The following is a description of a gene set: species: Homo sapiens Thickened toenails. Onychogryphosis of toenails Human Gene Set: HP_ONYCHOGRYPHOSIS_OF_TOENAILS, and this is the list of marker genes: COL7A1, KLHL24, KRT6B, PLEC, KRT16, KRT17, KRT6A